Given this list of marker genes EZH1, AHNAK, NBPF1, PAQR8, SUN2, MARF1, BORCS6, CYSLTR1, LINC01949, CDKN1C, NTNG2, CTNNB1, FBXL20, ADH4, MBP, SIRT2, NR1D2, TSC22D3, ITM2C, FGFBP2, LINC02481, DPEP2, HBP1, PWWP2B, ZNF33B, APBB1, SPON1, PRRC2B (proline rich coiled-coil 2B), CCDC88C, CREBRF, B3GALT4, C3AR1, ATP2B4, EVI2B, STK38, SDHAP2, GAB3, GRAP, RGS2, LAPTM5, AP1G2, SMAD7, GIMAP4, FTH1P5, TEPSIN, CSF3, SESN1, KIAA0513, IRAG2, ACP5, SORBS3, EDAR, GAL3ST4, FCMR, PLEKHB1, PLEKHA2 (pleckstrin homology domain containing A2), FAM219B, GRAMD1C, MED13L, ATM, HPCAL4, WNT7A, C1orf21, TP53INP1, NOL12, FTH1, PIK3R1, PRMT2, VAMP2, CASP8, LINC01138, PCMTD1, RPS27L, DHRS1, TFPI, WSB1, FHIP2B, PITPNC1, RBAK, BTN3A3, GIMAP1, VAMP1, ANXA1, TNNI2, GTSE1, C2orf68, PLAC8, IL7R, PDE3B, P2RY10, S1PR4, KLF3, FYB1, OPTN, TLE4, JMJD1C-AS1, CDC25B, SNPH, GIMAP2, USP35, CYTH4, ANXA2R, ITGB7, MAL, SYNJ2BP, KLRB1, NDRG3, BTN3A1, ZER1, NUMA1, TBC1D10C, ABI2, AUTS2, ARRDC3, PIK3IP1, NDE1, CYTH3, PDK3, PHC1, ADRB2, C16orf54 (NCBI Gene Id 728070), SYNE2, PNRC1, PLAAT4, TTC9, YPEL5, XPC, YPEL2, ST3GAL5, FOXO4, GDPD3, RIPOR2 (NCBI Gene Id 9750), ARL4C, ZNF222, FDXR, ARHGEF3, ARHGEF1 (NCBI Gene Id 9138), OTULINL, MAP3K1, RABGAP1L, CCNG2, CBY1, LDLRAP1, FAM8A1, S100PBP, NBR2, CLEC2B, EHD1, PNISR, PIDD1, CXCR4, ING4, RIMKLB, SLC26A11, TMEM94, NLRC5, MXI1, ID3, TECPR1, TMEM191A, GVINP1, ZNF550, P2RY8, EPC1, FAM167A, ZFP36L2, ZMAT3, WHAMM, NDRG1, CAMSAP2, VNN3P, PBXIP1, SOX6, H2AC6 (NCBI Gene Id 8334, H2A clustered histone 6), PRSS53, TNFRSF10B, MXRA7, TSPOAP1, ARRDC2, ORAI3, PFKFB4, NRIP2, MIR23AHG, NLRC3, MICAL1, GIMAP6, MIAT, PDE4D, TBCD, CASTOR3P, EEIG1, SMIM14, MEF2D, IPCEF1, PLXND1, here is a description of the gene set: species: Homo sapiens from publication Peltier DC, Simms A, Farmer JR, Miller DJ (PMID 20483728) Genes down-regulated in immature neuron cell line: control versus interferon alpha (6h). Human Gene Set: GSE16450_CTRL_VS_IFNA_6H_STIM_IMMATURE_NEURON_CELL_LINE_DN Human neuronal differentiation alters responsiveness to innate immune stimuli and virus infections. We used microarrays to examine the transcriptional responses of the human BE(2)-C neuroblastoma cell line to retinoic acid-induced differentiation and type I IFN stimulation.